The following is a description of a gene set: Mouse Gene Set: REACTOME_FATTY_ACIDS studied in species Mus musculus Fatty acids, and this is the list of marker genes: Cyp4a10, Cyp2a4, Cyp2j6, Cyp4f14, Cyp4a12b, Cyp4a30b, Cyp2a12, Cyp2d22, Cyp2b23, Cyp4a31, Cyp2f2, Cyp4a12a, Cyp4a29, Cyp4f15, Cyp2a5, Cyp4f18, Cyp2a22, Cyp4f39 (NCBI Gene Id 320997), Cyp4f40, Cyp4a32, Cyp4a14, Cyp4b1